The following is a description of a gene set: A cellular process that results in the aggregation, arrangement and bonding together of a set of components to form a tight junction. A tight junction seals cells together in an epithelium in a way that prevents even small molecules from leaking from one side of the sheet to the other. species: Homo sapiens Human Gene Set: GOBP_TIGHT_JUNCTION_ASSEMBLY, and this is the list of marker genes: STRN, CLDN11, EPHA2, CLDN7, PATJ, PECAM1, CLDN10, CLDN3, TNF, MARVELD2, OCEL1, GRHL2, IL17A, TJP1, POF1B, ACVRL1, CDH5, RPS6, ROCK2, CLDN23, ECT2, IKBKB, CLDN1, MPDZ, SNAI1, CLDN15, RAMP2, GDF2, CLDN25, CLDN16, AFDN, CLDN14, FZD5, OCLN, DSG3, ARL2, ESAM, DLG1, MARVELD3, LSR, CLDN19 (claudin 19), WNT11, MICALL2, ILDR1, CLDN22, CLDN8 (claudin 8), ACTG1, SRF, NPHP1, CLDN17, PRKACA, MIR105-1, CLDN2, CLDN34, ROCK1, APC, SLC39A9, CLDN5, PRKCH, GPBAR1, EPHB2, NPHP4, CLDN9, CLDN4 (NCBI Gene Id 1364), MPP7, CLDN12, SNAI2, TBCD, CLDN20, PARD3 (NCBI Gene Id 56288), FRMPD2, CLDN24, PAK2, CLDN18, RAB13, MIR142, MYO1C, RAC1, F11R, PDCD6IP, CLDN6